The following is a description of a gene set: Prolonged ERK activation events studied in species Mus musculus Mouse Gene Set: REACTOME_PROLONGED_ERK_ACTIVATION_EVENTS, and this is the list of marker genes: Rapgef1, Mapk1, Frs2, Mapk3, Ywhab, Map2k1, Crk, Map2k2, Rap1a, Kidins220, Crkl, Ngf, Braf, Ntrk1